Given this list of marker genes SGK1, DDX3X, MDM1, BCL11A, CXXC5, RTRAF (RNA transcription, translation and transport factor), NDUFV2, NRG1, FBN1, IPO5, DDX3Y, STC2, PARP12, PURG, CCP110, RIOK3, SOX12, BRSK2, WNT5A, NR4A3, ATP2A3, THADA, ASXL2, ST8SIA2, LIN7C, ARHGEF5, NHS (NCBI Gene Id 907, NHS actin remodeling regulator), BPTF, IGF2, FAF1, RERE, FBXL19-AS1, RSU1, BACH2, NFXL1, BCL11B, BTG1, LRRC75A, CLOCK, ADAMTS13, EIF4A1, UBXN4, OXR1, PDE4D, BAALC, ARHGAP36, SRGAP2, TTN, UNC5D, RBM12, RARB, TSC22D2, ADAMTS5, NCOA1, OPN3, WASHC4, XPO1 (exportin 1), NLK, SOX30, PPP1CB, SCN3A, ATRX, ARID5A, DCX, POU3F2, TRIB2, ITGB8, MBD6, BMP7, JADE2, RBBP6, FYTTD1, PCDH10, PTGR3, MAP7D2, CELF1, ATP2B3, NOVA1, NSD1, FAM76B, PRSS23, SP4, EMC7, GPD1, CCDC178, SMAD3 (NCBI Gene Id 51521), SNX3, NTRK3, HUNK, here is a description of the gene set: Human Gene Set: ATGTCAC_MIR489 Genes having at least one occurence of the motif ATGTCAC in their 3' untranslated region. The motif represents putative target (that is, seed match) of human mature miRNA hsa-miR-489 (v7.1 miRBase). species: Homo sapiens